Given this list of marker genes Gtf2f2, Prpf18, Snrpa1, Phf5a, Polr2a, Ppil2, Snu13, Dhx16, Fam32a, Luc7l3, Sart1, Lsm2, Sf3a3, Magoh, Prcc, Prkrip1, Srrt, Usp39, Dhx35, Magohb, Srsf3, Prpf19, Sugp1 (SURP and G patch domain containing 1), Mfap1a, Nkap, Cwc27, Cdc5l, Rbmx, Hnrnpf, Xab2, Tfip11, Hnrnph2, Eftud2, Ppil1 (NCBI Gene Id 68816), Snrpc, Polr2b, Cactin, Rnf113a1, Pcbp1, Mtrex, Snrnp27, Ddx41, U2af2, Ptbp1, Ctnnbl1, Lsm6, Snrpf, Snrpg, Polr2f, Bud13, Hnrnph1, Sde2, Sf3b5, Alyref, Srrm2, Srsf10, Nsrp1, Lsm4, Snip1, Rbm17, Wbp4, Polr2e, Lsm8, Dhx8, Zfp830, Polr2i, Snw1, Hnrnpr, Ik, Cdc40, Rbm5, Polr2c, Prpf4, Ppig, Smndc1, Upf3b, Pcbp2, Polr2l, Syf2, Srsf5, Rnps1, BC005624, Snrpn, Casc3, Mfap1b (microfibrillar-associated protein 1B), Ubl5, Steep1, Rbm22 (NCBI Gene Id 66810), Snrnp40, Snrpa, Ddx23, Polr2k, Srsf8, U2surp, Hnrnpk, U2af1l4, Yju2, Gpatch1, Gtf2f1, Leng1, Prpf3, Dhx15, Rnf113a2, here is a description of the gene set: This event has been computationally inferred from an event that has been demonstrated in another species.<p>The inference is based on the homology mapping from PANTHER. Briefly, reactions for which all involved PhysicalEntities (in input, output and catalyst) have a mapped orthologue/paralogue (for complexes at least 75% of components must have a mapping) are inferred to the other species. Reactome Pathway: mRNA Splicing - Major Pathway electronically inferred by orthology from the curated human pathway studied in species Mus musculus part of: mRNA Splicing